The following is a description of a gene set: studied in species Homo sapiens Human Gene Set: GOBP_CONVERGENT_EXTENSION The morphogenetic process in which an epithelium narrows along one axis and lengthens in a perpendicular axis., and this is the list of marker genes: VANGL2, PTK7, WNT5A (Wnt family member 5A), WNT5B, SFRP1, NPHP3, DVL1 (dishevelled segment polarity protein 1), DVL2, LBX2, NKD1, FRZB, WNT11, SFRP2, MKKS, MESP1, TRIM28